The following is a description of a gene set: Any process that modulates the frequency, rate or extent of megakaryocyte differentiation. species: Mus musculus Mouse Gene Set: GOBP_REGULATION_OF_MEGAKARYOCYTE_DIFFERENTIATION, and this is the list of marker genes: Cnot4, Pithd1, Prmt1, Pf4, Kdm1a, Faxdc2, Gata2, Scin, Cib1, L3mbtl1, Gabpa, Hmgb2, Eif6 (eukaryotic translation initiation factor 6), Tesc, Myb (myeloblastosis oncogene), Rbm15, Lox, Rcor1, Mef2c, Rab7b, Mturn, Tescl, Thpo